Given this list of marker genes DCTD, FUOM, APRT, ADK, AMPD2, PDXK, DNPH1, PRTFDC1, DCK, MTAP, UPP1, ADI1, UCKL1, UCK2 (uridine-cytidine kinase 2), PGM2, APIP, HPRT1, ENOPH1, QNG1, NAPRT, UCK1, PNP, ADSS1, UPP2, FCSK, BHMT, CDA, AMPD1, AMPD3, TK2, BHMT2, SLC35C1, ADA, DGUOK, ADSL, here is a description of the gene set: studied in species Homo sapiens Human Gene Set: GOBP_METABOLIC_COMPOUND_SALVAGE Any process which produces a useful metabolic compound from derivatives of it without de novo synthesis, as carried out by individual cells.